Given this list of marker genes VPS53, PUS3, CASP2 (NCBI Gene Id 835), RALBP1, NRIP3, ATP1B1, C8orf58, RPL28, SLC6A15, CYTL1 (cytokine like 1), PLXDC2, PHTF2, SERPINB13, AGPAT3, MEX3B, CFAP90, RALGPS2, TP63, CDC42BPA, SH3PXD2A, CAMTA1, TTC39C, GRIK2, SMUG1, RPP14, TMEM215, TMED1, CALN1, EDN2, PEAR1, MED19, HOMER1, NR2C2, PCDH17, PAX5, TOGARAM1, RFWD3, NPNT, INO80D, ARMCX3, CCND1, ZNF708, ADORA2B, ANKH, MYO1F, MORC3, GPD2, EVC, TMEM201, SRSF7, PTPRJ, KIF1C, FAM168A, RRP15 (ribosomal RNA processing 15 homolog), TANC2, CUTC, C19orf73, CPLX2, SHISAL1, TRABD2B, RIC3, WDR31, ZSCAN5A, LSM5, GGCX, TNRC6B, A1CF, CMTR1, UBE2QL1, OGG1, ZFR2, CRKL, TMEM95, INSIG2, UBIAD1, NXF1, SORCS1, MBNL1, here is a description of the gene set: Genes predicted to be targets of miRBase v22 microRNA hsa-miR-221-5p in miRDB v6.0 with MirTarget v4 prediction scores > 80 (high confidence targets). from publication Chen Y, Wang X (PMID 31504780) Human Gene Set: MIR221_5P species: Homo sapiens